The following is a description of a gene set: studied in species Mus musculus Mouse Gene Set: chr4C2, and this is the list of marker genes: Gm11224, Gm11221, Gm11228, Gm11232, Gm11231, Megf9, Ywhaq-ps3, Gm11223, Gm11227, Rps18-ps1, Cdk5rap2, Gm11225, Gm11222